Given this list of marker genes Haus1, Nde1, Cep57, Plk1, Cep152, Prkar2b, Haus8, Haus5, Tuba4a, Ywhae, Tubgcp6, Sdccag8, Tubb4b (tubulin, beta 4B class IVB), Haus7, Clasp1, Cdk1, Dctn1, Cep63, Tuba1a, Cdk11b, Actr1a, Cep43, Cep131, Cenpj, Tubb4a, Tubgcp2, Dynll1, Sfi1, Prkaca, Cep192, Cep135, Cep72, Cep290, Nedd1, Cep41, Mzt1, Csnk1e, Tubgcp3 (tubulin, gamma complex component 3), Ninl, here is a description of the gene set: part of: Centrosome maturation electronically inferred by orthology from the curated human pathway Reactome Pathway: Recruitment of mitotic centrosome proteins and complexes studied in species Mus musculus This event has been computationally inferred from an event that has been demonstrated in another species.<p>The inference is based on the homology mapping from PANTHER. Briefly, reactions for which all involved PhysicalEntities (in input, output and catalyst) have a mapped orthologue/paralogue (for complexes at least 75% of components must have a mapping) are inferred to the other species.